The following is a description of a gene set: studied in species Mus musculus The chemical reactions and pathways resulting in the formation of quinone. Mouse Gene Set: GOBP_QUINONE_BIOSYNTHETIC_PROCESS, and this is the list of marker genes: Pdss1, Coq8b, Coq3, Coq6, Coq9, Adck2, Coq4, Coq5, Ubiad1, Coq2, Rtn4ip1, Pptc7, Pdss2, Coq7, Coq8a, Ndufa9